Given this list of marker genes DVL3, DVL2, CCDC88C, CXXC4, DVL1, here is a description of the gene set: part of: TCF dependent signaling in response to WNT Reactome Pathway: Negative regulation of TCF-dependent signaling by DVL-interacting proteins DVL is a central component of WNT signaling that plays roles in both canonical and non-canonical pathways. In the canonical pathway, DVL recruits AXIN from the destruction complex upon WNT stimulation, allowing cytosolic beta-catenin to accumulate. DVL activity is regulated by phosphorylation as well as by regulated proteasomal or lysosomal degradation. In addition, DVL activity can be regulated by interaction with other proteins; both CXXC4 and CCDC88C were identified as negative regulators of WNT signaling that interact directly with DVL, although the role of these proteins in limiting WNT signaling remain to be fully worked out. studied in species Homo sapiens